Given this list of marker genes SEPTIN5 (NCBI Gene Id 5413), CSPG5, HLA-F, CD300A, PRAM1, TSPAN18, NCKAP1L, SYNJ1, STXBP2, RAP1B, SCRIB, TMEM79, SNAP29, SDF4, PFN2, BRSK1, STX1B, SNAPIN, CEACAM1, SNAP47, BLOC1S6, UNC13B, GPR15LG, CDK5, CD84, NLRP5, DTNBP1, GATA2, STX1A, NKG7, CBARP, ANXA3, CACNB4, GRIK5, BAIAP3, EQTN, SYT4, RAB15, STXBP3, ZP3, ATP2A2, STX2 (syntaxin 2), LGALS9, MRGPRX2, NAPB, MILR1, PLEK, SYNGR1, P2RX1, CLTRN, PRRT2, CDK5R2, UNC13A, PPFIA3, SYT3, SV2B, CPLX1, FCGR2B, DNAJC5, RABGEF1, RIMS1, SNPH, LAT2, RAP1A, HCK, VPS18, VAMP3, SYK, CD160, LRRK2, ADORA2B, OSBPL2, RIMS2, CPLX3, RAB10, RAP1BL, SLC4A8 (solute carrier family 4 member 8), PCLO, SYT13, SNX4, IL4R, RPH3AL, PIK3CD, PIK3CG, DOC2B, ABCA12, CRHBP (corticotropin releasing hormone binding protein), RAB44, IGHE, CBL, ITGB2, HYAL3, VAMP8, PPP3CB, FCGR3A, SYT8, VAMP7, RPH3A, LAMP1, LYN, CALM3, SYT2, SCN11A, SNCA, CD177, FMR1, SYT1, PSEN1, RAB26, SNX6, TPRG1L, CCL3, KCNB1, CLNK, AP1G1, IL13RA2, STX4, RIMS4, STX19, SYN2 (NCBI Gene Id 6854), RAB31, SCIN, FOXF1, NOTCH1, FBXL20, P2RX7, PDPK1, GATA1, SYP, REST, FES, SYT12, PRKCB, SNAP25, DVL1, RAB11FIP5, RAPGEF4, CHGA, RAC2, WNT7A, NAPA, IL13, ITGAM, TPH1, FCER1A (Fc epsilon receptor Ia), PRKCG, NLGN1, STXBP1, NR4A3, SYN1, RAB3GAP1, SYT5, SNAP23, SLC18A2, CPLX4, FERRY3, SPI1, CADPS2, SYT9, STX11 (syntaxin 11), FBXO45, RAB5A, CCR2, P2RY1, KIT, SYT10, CPLX2, NPY, PTGDR, ABCC4 (NCBI Gene Id 10257), DOC2A, RAB3D, CASK, MYH9, RAB27A, SYT7, CORO1A, ARL8B, RAB11B, PREPL, PPP3CA, ADRA2A, BTK, VAMP2, LAT, MICAL1, GAB2, GRP, SCAMP5, SV2A, UNC13D, PTGDS, TMED10, FCER1G, SV2C, PIP5K1C, UNC13C, RAB3A, GIT1, SYT15, F2RL1, OTOF, ZP4, CADPS, PLA2G3, STXBP5, BCR, ERC2, FGR, SYT17, BRAF, TRPV6, SYT11, SYNGR2, RAB11FIP2 (NCBI Gene Id 22841), EFR3A, RAB11FIP1, RASGRP1, GPR151, GNAI2, SYNGR3, SYT6, CACNA1B, KLRC2, SPHK2, RIMS3, S100A13, STEAP2, PPFIA2, KLRF2, ADGRE2, here is a description of the gene set: species: Homo sapiens Human Gene Set: GOBP_REGULATED_EXOCYTOSIS A process of exocytosis in which soluble proteins and other substances are initially stored in secretory vesicles for later release. It is found mainly in cells that are specialized for secreting products such as hormones, neurotransmitters, or digestive enzymes rapidly on demand.